Given this list of marker genes ACAT1, HMGCL, HMGCS2, ACSS3, AACS, BDH1, BDH2, HMGCLL1, here is a description of the gene set: Synthesis of Ketone Bodies Human Gene Set: REACTOME_SYNTHESIS_OF_KETONE_BODIES species: Homo sapiens